The following is a description of a gene set: The progression of the olfactory lobe over time from its initial formation until its mature state. The olfactory lobe is the area of the brain that process the neural inputs for the sense of smell. Mouse Gene Set: GOBP_OLFACTORY_LOBE_DEVELOPMENT species: Mus musculus, and this is the list of marker genes: Slit1, Mir200b, Sec1, Sall3, Rac1, Atf5, Chd7, Erbb4, Sema3a, Dicer1, Slit2, Fezf1, Wnt5a, Nr2e1, Robo1, Mir141, Zic3, Mir9-1, Crtac1 (cartilage acidic protein 1), Lrrk2, Pcnt, Id2, Sall1, Fgfr1, Dlx5, Ogdh, Mir200a, Dlx2, Gsx2, Fut1, Mir429, Mir9-2 (microRNA 9-2), Ttc8, Rpgrip1l, Sema7a, Csf1r, Agtpbp1, Lhx2, Pax6, Ext1, Robo2, Htt, Mir376a, Kif14, Arx, Uncx, Zic1, Srf, Mir200c, Nfix, Efna2, Eomes, Atp1a2, Mecp2, Ski, Mir9-3